Given this list of marker genes CD180, UNC93B1, SCD, HTR6, PPARG, FCGR2B, KLRG1, LY6D, MYC, EGR2, PES1, ETFB, CFAP144P1, KLF1, FCHSD2, IRF8, TNF, WDHD1, PROS1 (NCBI Gene Id 5627), DNMT1 (NCBI Gene Id 1786), ATL2, PMAIP1, SMARCC1, PMF1, GNL3L, URM1, HADHA, DEPDC1, NOL10 (nucleolar protein 10), SEMA7A, CYBB, RCL1, SPG21, WDFY4, PLEK, RTN4IP1, ABRAXAS1, SYPL1, INTS2, LRSAM1, TMEM167A, PPP1R7, PLD4, HMGN3, SERPINE2, TNFRSF18, SEC11C, ESCO2, RNF41, DTYMK, PAQR3, IRAG2, SULT6B1, MIR155, RAD54L, ST6GALNAC4, MCRS1, BCAR3, ABI2 (NCBI Gene Id 10152), RNASE6, SMC3, CBX5, CDC20, KCNMA1 (potassium calcium-activated channel subfamily M alpha 1), TNFRSF4, IPO11, EIF5B, PHACTR4, TIGD3, NEK2, FCMR (NCBI Gene Id 9214), CCDC50, TOP1MT, TMEM138, ECM1, CD80, IL21R, S100A1, THEMIS2, RALGPS2, PAX5, ALKBH6, CAPG, METAP1, GEN1, KIF18A, NR4A1, CTSH, SRPK3, CD83, TNNC1, CD79B, ZNF106, SPC24, NTRK3, SEMA4C, RFC1, MRE11, B9D1, IQGAP3, C1orf54, MS4A1, MRPL2, MIPEP, MAEA, CD74, PLK2, ECH1, RGS12, SAMSN1, DDX1, MIR212, AEN, LY86, LYN, CLTB, MCM10, MEF2C, SMARCB1, ACOT7, IFI30, CD19, SCPEP1, CCL4, VANGL2, BLK, MSRB3, ACADL, SH3BGRL, KPNA1, ST13, MIR31, NAPSA, SLC25A19, BLNK, CNOT9, E2F7, TNFRSF13C, KIF20B, EXOC4, EXOSC9, LARP4, GAS2, CHD1, TFPI, PHKA2, SWAP70, BID, CISH, CEP170, SLAMF7, RASGRP4, CD79A, GSTT1, PCDHB1, GSTT2, PIK3R6, CKS1B, RAD51B, ADNP2, ZCWPW2 (zinc finger CW-type and PWWP domain containing 2), GPLD1, PTPN6, NFKBIZ, CD38, AGA, PASK, RPF2, D2HGDH, SLAMF9, here is a description of the gene set: Genes down-regulated in CD4 T cells: naïve versus Th1. In this study, we examined differential gene expression in naïve human CD4+ T cells, as well as in effector Th1, Th17-negative and Th17-enriched CD4- T cell subsets. We observed a marked enrichment for increased gene expression in effector CD4+ T cells compared to naive CD4+ among immune-mediated disease oci genes. Within effector T cells, expression of disease-associated genes was increased in Th17-enriched compared to Th17-negative cells. We used microarray to examine the gene expresssion profile and level of human naïve, Th1 and effector T cell subsets. Human Gene Set: GSE32901_NAIVE_VS_TH1_CD4_TCELL_DN from publication Zhang W, Ferguson J, Ng SM, Hui K, Goh G, Lin A, Esplugues E, Flavell RA, Abraham C, Zhao H, Cho JH (PMID 22715389) studied in species Homo sapiens